The following is a description of a gene set: Any process that results in a change in state or activity of a cell (in terms of movement, secretion, enzyme production, gene expression, etc.) as a result of a light intensity stimulus. Human Gene Set: GOBP_CELLULAR_RESPONSE_TO_LIGHT_INTENSITY studied in species Homo sapiens, and this is the list of marker genes: AKT2, GNB5, SLC24A4, RGS9, SLC24A2